The following is a description of a gene set: The process in which a relatively unspecialized precursor cell acquires specialized features of a lymphocyte. A lymphocyte is a leukocyte commonly found in the blood and lymph that has the characteristics of a large nucleus, a neutral staining cytoplasm, and prominent heterochromatin. Human Gene Set: GOBP_LYMPHOCYTE_DIFFERENTIATION studied in species Homo sapiens, and this is the list of marker genes: LAG3, SPIB, SASH3, IRF2BP2, MMP14, HLA-DOA, IL4I1, GATA3, ITM2A, RHOH, MFNG, DLL4, IL1A, KMT2A, FOXO3, TSC1, PIK3R3 (phosphoinositide-3-kinase regulatory subunit 3), PRR7, DDRGK1, STAT4, CD79B, IL6R, SMARCD1 (NCBI Gene Id 6602), ATF2, CCR7, CLEC4E, THEMIS, EP300, GBA1 (NCBI Gene Id 82008), JUNB, PPP3CB, PDP2, JAK3 (NCBI Gene Id 3718), JMJD6, ADAM8, NFKBID, ITFG2, FOXP1, RPL22, BRD4, SOX12, ZBTB7A, PRDM1, VCAM1 (NCBI Gene Id 7412), FOXN1, CARD11, SLC25A5, LGALS1, TBX21, ICOS, SMARCC1, IL23R, ADAM10, AICDA, TAOK3, IL4, SPN, SMARCA2, FZD9, GPR89B, LYL1, NFATC3, AP3D1, IL7R, LGALS9, PREX1, FCER1G, CD3G, CDK6, RUNX1, LRRC8A, PCK1, C17orf99, STAT5A, FOSL2, ICOSLG, CD74, B2M, TNFSF8, VNN1, NOTCH2, IKZF3, CD3D, HHEX, BCL3, POLM, IL15, BCL2, BTK, CLPTM1, AMBRA1, HDAC9, SOS1, ZBTB1, NKAP, ABL1 (ABL proto-oncogene 1, non-receptor tyrosine kinase), RABL3, HLX, ZMIZ1, SHB, SFRP1, XBP1, ENTPD7, TYRO3, PIK3R6, PHF14, ARID2, SLAMF1 (NCBI Gene Id 6504), FLT3, MIR17HG, PPP2R3C, SOCS3, ITK, PSMB11, DUSP10, ARID1B, CD2, EOMES, BLNK, DCAF1, FZD8, CBFB, CTLA4, GPR183, INHBA, CD27, LEP, FUT7, BAK1, ZFP36L1 (NCBI Gene Id 677), CHD7, ADA, CYLD, IL18 (interleukin 18), HMGB3, WNT10B, BAD, BATF, POU2AF1, CD79A, SLC39A7, CAMK4, USP44, RUNX2 (RUNX family transcription factor 2), STAT3, PSG9, MIR30B, ZFPM1 (NCBI Gene Id 161884), ATP7A, NCKAP1L, IL18R1, ZAP70, PHF10, FANCD2, IHH, STAT5B, IL1RL2, MS4A1 (NCBI Gene Id 931), SYVN1, XRCC6, ITPKB, BRAF, CTNNB1, JAG2, CCR6, NTRK1, TOX, PAX5, CD4, WNT4, PIK3R2, TNFSF18, GPS2, SRF, RORA, SLC46A2, LIG4, ITPRIPL1, ARMC5, PRKDC, KAT5, PGLYRP3, SOCS5, RC3H1, SMARCD3, BRD7, CCL19, CYP26B1, NRARP, IL23A, KLRC1, CD69, SYK, BAX, CTSL, DNAJA3, PTPN2, SOX13, TBK1, HDAC4, SHH, TGFB1, SH3RF1, IL11, IL2RG, FBXO7, FGL2, RORC, LEPR, ACTL6B, TMEM131L, IL4R, SLAMF8, IFNB1, KLHL25, FANCA, PCID2, ITGA4, SMARCC2, LILRB4, ZC3H12A, AQP8, IL6, LEF1, VAV1, KCNK18, FOXP3, LY6D, TCIRG1, IL27, HLA-DRB1, NFAM1, RHOA, DNAJB9, LOXL3, PIK3R1, RC3H2, KAT2A, LMBR1L, CD80, ZC3H8, TUSC2, TNFSF9, IL36B, CDKN2A, TRAF3IP2, NLRP3, SMARCB1, PTCRA, IRF1, ZBTB16, FOXJ1, SOD1, IL2RA, NFKBIZ, ZBTB7B, GAS6, SMARCA4, PGLYRP2, VSIR (NCBI Gene Id 64115), GLI2, RAG1, IL2, IRF8, FCGR2B, NFIL3, BCL11B, CLCF1, KLF6, ATG5, GPR89A, EZH2, LCK, STK11, PNP, DCLRE1C, RELB, PTPRJ, MAFB (NCBI Gene Id 9935), IL12RB1, CD19, PLA2G2D, KAT7, CCR9, CLEC4D, CD3E, CD40LG, CD86, TNFSF4, RARA, NDFIP1, IL15RA, MSH2, IFNA2 (NCBI Gene Id 8005), TP53, RASGRP1, RIPK2 (NCBI Gene Id 8767), RAG2, GPR18, SLC4A2, PRELID1, MIR21, MTOR, CMTM7, FZD5, PBX1, FLT3LG, PLCG2, ACTL6A, MDK, AIRE, BMI1, IL6ST, AP3B1, PIK3CD, OPA1, CRTAM (NCBI Gene Id 56253), AXL (AXL receptor tyrosine kinase), MALT1, FZD7, TLR9, GLI3, CD1D, ONECUT1, SOS2, LY9, ID2, TMEM98, PLCL2, CD46, TCF7, JAK1, SMARCD2, TOP2B, CDH17, ACTB, ATM, BMP4, KIT, TESPA1, PTPN6, TPD52, ZFP36L2, SOX4, PKNOX1, IL9, ASCL2, PRDX2, ST3GAL1, DOCK11, MYB, DROSHA (NCBI Gene Id 54746), TCF3, INHA, CEBPG, SMAD7, DLL1, BTN2A2, CRACR2A, HLA-G, IL21, IL12B, DTX1, CD83, METTL3, MR1, IKZF1, ARID1A, ADAM17 (NCBI Gene Id 6868), CD8A, HDAC5, PBRM1, CR1, LILRB2, SLAMF6, EGR3, LFNG, RUNX3, IFNG, IRF4, NCAPH2, DOCK2, PTPN22, IL7, NHEJ1, SMARCE1, ZNF683, WNT1 (NCBI Gene Id 7471), ITGB1, FNIP1, RNF41 (ring finger protein 41), PRKCZ, MERTK, TGFBR2, MEN1, LGALS8, IFNL1, GPR65, SEMA4A, FCRL3, TNFRSF9, ZEB1, PATZ1, PTGER4, CR2, KDELR1, ANXA1, TNFSF13B, IL1B, FADD (NCBI Gene Id 8772), SP3, HMGB1, BRD2, SOCS1, CCR2, SART1, DOCK10, NKX2-3, EGR1, INPP5D, BCL6 (NCBI Gene Id 604), LIPA, ERBB2, PTPRC, YY1, ADGRG3 (NCBI Gene Id 58870), RBPJ, PTK2B, SPI1, IL10, HLA-DRA, PGLYRP1, STAT6, LAPTM5, CLEC4G, RSAD2, SPINK5, IGHM, RIPK3, CD28